The following is a description of a gene set: Dendritic cells (DCs) in lymphoid tissue comprise conventional DCs (cDCs) and plasmacytoid DCs (pDCs) that develop from common DC progenitors (CDPs). CDPs are Flt3+c-kitintM-CSFR+ and reside in bone marrow. Here we describe a two-step culture system that recapitulates DC development from c-kithiFlt3-/lo multipotent progenitors (MPPs) into CDPs and further into cDC and pDC subsets. MPPs and CDPs are amplified in vitro with Flt3 ligand, stem cell factor, hyper-IL-6 and insulin- like growth factor-1. The four-factor cocktail readily induces self-renewal of MPPs and their progression into CDPs and has no self-renewal activity on CDPs. The amplified CDPs respond to all known DC poietins and generate all lymphoid tissue DCs in vivo and in vitro. Additionally, in vitro CDPs recapitulate the cell surface marker and gene expression profile of in vivo CDPs and possess a DC-primed transcription profile. Transforming growth factor-β1 (TGF-β1) impacts on CDPs and directs their differentiation towards cDCs. Genome-wide gene expression profiling of TGF-β1-induced genes identified transcription factors, such as interferon regulatory factor-4 (IRF-4) and RelB, that are implicated as instructive factors for cDC subset specification. TGF-β1 also induced the transcription factor inhibitor of differentiation/DNA binding 2 (Id2) that suppresses pDC development. Thus, TGF-β1 directs CDP differentiation into cDC by inducing both cDC instructive factors and pDC inhibitory factors. Human Gene Set: GSE22432_UNTREATED_VS_TGFB1_TREATED_COMMON_DC_PROGENITOR_UP from publication Felker P, Seré K, Lin Q, Becker C, Hristov M, Hieronymus T, Zenke M (PMID 20881193) Genes up-regulated in cultured common dendritic cell progenitors: untreated versus TGFB1 for 4h. studied in species Homo sapiens, and this is the list of marker genes: UBR7, SYMPK, TEN1, THAP4, ACP2, MNT, DNMT3A, ATG2A, TMEM120A, SCARB2, PDLIM4, RNF31, PARP8, SLC6A12, FLYWCH1, PGM1, PENK, BST2, STXBP1, FANCA, RGS1, C3orf38, NCF4, NUAK2, UTP3, PHOSPHO2, CCNI, ADGRV1, INHBE, NHLRC1, IQUB, PWWP2B, CRH, MISP, HPSE, LEPROTL1, EXOC7, TBC1D10C, CEP95, ACOX3, RAB11A, WIPI2 (NCBI Gene Id 51623), TAF8, UBL7, BBS2, TMCO3, GAB2, TSPOAP1 (NCBI Gene Id 9256), CDC34, MAPK7, DNAH2, EIF4A2, ASB6, LGALS3BP, UBC (ubiquitin C), ZNF32, PCED1B, TMEM39B, SURF1, OAS3, SCFD1, APOBEC1, SLAMF8, DUSP10, ANKRD23, TMEM216, YJU2, PEX16, SUMF1, STX18, PLIN3, ZBTB43 (NCBI Gene Id 90789), MMP2, LOXL3, NRBF2, TRIM7, MTARC2 (NCBI Gene Id 96692), GNB3, SPSB3, MAPKAP1, SPHK1, SLC26A11, RANBP9, TMBIM4 (NCBI Gene Id 51643), H2BC3, ZNF704, APPL2, GRM5, AFMID, MAD2L1BP, PER1, ZBP1, CNP, UBAC2, GPR15, CD86, COPS4, NTS, PABIR2, CFAP210, REEP1, FKBPL, STXBP2, DENND1A, ZNF414, STOML1, RLBP1, RAB13, EXOC6, IRF7, FOXK1, GTPBP2, SUPT4H1, STK40, CNNM2, UBTD1, P4HA2, CLN8, NBDY, IRGC, DPYSL2, HTR2B, ELMOD3, MRPL47, ADAM33, TTC12, LYRM1, TRIM41, MOCS2, ENPP4, PTTG1, STX8, HLA-G, CLPX, IL12RB1, TAF5L, RRBP1, CXXC5, TCIRG1, PRPF38A, NBR1, VEGFA, PANK2, WDR25, TLR1, NUDT13, TSTD2, RDM1, TAB1, DPEP1, CHIC1, TCAIM, KNOP1 (NCBI Gene Id 400506), TMUB2, GOLPH3L, TOM1L2 (target of myb1 like 2 membrane trafficking protein), SELPLG, DAPK3, ZC3H6, PDE7B, GLA, FBXO7, TRIT1, NSRP1, GKAP1 (G kinase anchoring protein 1), TNFRSF9, IFT56, PDGFRL, TPGS1 (tubulin polyglutamylase complex subunit 1), GTDC1, STX4, TMEM202, PRKD2, ADIPOR1 (NCBI Gene Id 95409), LY86, CCT8L2, BAIAP2, MIP, MAP4K2, KBTBD3, EAF2, GORASP1, HOOK2, HPDL, GATAD2B, SLAMF6, LRP4, PTDSS2, FLT4, EAPP, RIGI, SLC6A19, DXO, LIMK2, TSPO, ZNHIT2, SLC25A19, C14orf180, IFT22, SELENOW